The following is a description of a gene set: species: Homo sapiens Signaling by NOTCH3 Human Gene Set: REACTOME_SIGNALING_BY_NOTCH3, and this is the list of marker genes: HEY2, DLL1, PSENEN, EP300, EGFR, MAML2, DLGAP5, NOTCH3, CREBBP, JAG2, NOTCH1 (notch receptor 1), PSEN2, ADAM10, HEYL, STAT1, UBC, RBPJ, APH1A, NEURL1B, HES1, FABP7, MAML1, MIB2, WWP2, IKZF1, SNW1, TACC3, WWC1, MAML3, JAG1, PTCRA, UBB, KAT2A, UBA52, HES5, HEY1, MAMLD1, NCSTN, MIB1, RPS27A, YBX1, NEURL1, APH1B, DLL4, PLXND1, EGF, PBX1, PSEN1, KAT2B